Given this list of marker genes Duox2, Otx2, Tal2, Rbpj, Pitx2, Ncam1, Kcnc1, D130043K22Rik, Sox3, Ndnf, Lrp6, Gbx2, Fgf2, Bmpr1a, Plxna3, Prdm13, Pitx1, Gli2, Mecp2, Wnt1, Pou3f2, Six3, Gata2, Nrp1, Bmp4, Hmga2, Isl1, Pou1f1 (POU domain, class 1, transcription factor 1), Ncor1, Srd5a2 (NCBI Gene Id 94224), Olig2, Pou4f1, Creb1, Prop1, Ptchd1, Plxna1, Tbx19, Inhbb, Ogdh, Kdm1a, Sema3e, Wnt5a, Ghrhr, Nkx2-6, Hesx1, Pax6, Slc6a3, Ncoa1, Foxb1, Lhx3, Nog, Fgf10, Bax, Nhlh2, Smo, Crh, Pcsk1, Otx1, Sox2, Uqcrq, Hes1, Sema3a, Nrp2, Drd2, Atp1a3, Tcf7l2, Kcnc2, Gli1, Ghrh, Zeb2, Hap1, Shh, Bmp2 (NCBI Gene Id 98992), Aldh1a2, Nkx2-1, Rab3gap1, Arx, Gsx1 (GS homeobox 1), Nr4a2, Bloc1s6, Rax, Ctnnb1, Fgf8, Wnt4, Ubb, Adcyap1, Sema5a, Chrnb2, Otp, here is a description of the gene set: studied in species Mus musculus Mouse Gene Set: GOBP_DIENCEPHALON_DEVELOPMENT The process whose specific outcome is the progression of the diencephalon over time, from its formation to the mature structure. The diencephalon is the paired caudal parts of the prosencephalon from which the thalamus, hypothalamus, epithalamus and subthalamus are derived; these regions regulate autonomic, visceral and endocrine function, and process information directed to the cerebral cortex.